Given this list of marker genes PPP1R1B (NCBI Gene Id 84152), FUOM, EDDM3A (epididymal protein 3A), DMRTA1, NPAS1, THRB, FEV, KLK14, NCOA1, SERPINE2, PI3 (peptidase inhibitor 3), ABAT, P2RX1, TH (NCBI Gene Id 7054), ACVR2A, APP, TACR1, SLC6A4, ZFY, EDNRB, PPP1R9B, DRD1, HCN1, ADA, SEMG1, NR3C1, GABRB3, MAPK8IP2, UBE2Q1, BRINP1, DDO, DBH, HEXB, AVPR1A (arginine vasopressin receptor 1A), OPRK1, HDAC2, AVP, GAL, DRD5, OXT, MBD2, THRA, TAC1, CREBRF, PTEN, P2RY1, MTNR1A, NHLH2, here is a description of the gene set: studied in species Homo sapiens Human Gene Set: GOBP_REPRODUCTIVE_BEHAVIOR The specific behavior of an organism that is associated with reproduction.